The following is a description of a gene set: Human Gene Set: MISHRA_CARCINOMA_ASSOCIATED_FIBROBLAST_UP Carcinoma-associated fibroblasts (CAF) have recently been implicated in important aspects of epithelial solid tumor biology, such as neoplastic progression, tumor growth, angiogenesis, and metastasis. However, neither the source of CAFs nor the differences between CAFs and fibroblasts from nonneoplastic tissue have been well defined. In this study, we show that human bone marrow-derived mesenchymal stem cells (hMSCs) exposed to tumor-conditioned medium (TCM) over a prolonged period of time assume a CAF-like myofibroblastic phenotype. More importantly, these cells exhibit functional properties of CAFs, including sustained expression of stromal-derived factor-1 (SDF-1) and the ability to promote tumor cell growth both in vitro and in an in vivo coimplantation model, and expression of myofibroblast markers, including alpha-smooth muscle actin and fibroblast surface protein. hMSCs induced to differentiate to a myofibroblast-like phenotype using 5-azacytidine do not promote tumor cell growth as efficiently as hMSCs cultured in TCM nor do they show increased SDF-1 expression. Furthermore, gene expression profiling revealed similarities between TCM-exposed hMSCs and CAFs. Taken together, these data suggest that hMSCs are a source of CAFs and can be used in the modeling of tumor-stroma interactions. To our knowledge, this is the first report showing that hMSCs become activated and resemble carcinoma-associated myofibroblasts on prolonged exposure to conditioned medium from MDAMB231 human breast cancer cells. Top genes up-regulated in mesenchyme stem cells (MSC) grown in a tumor conditioned medium, which leads to carcinoma-associated fibroblast phenotype. studied in species Homo sapiens from publication Mishra PJ, Mishra PJ, Humeniuk R, Medina DJ, Alexe G, Mesirov JP, Ganesan S, Glod JW, Banerjee D (PMID 18519693), and this is the list of marker genes: FOS, THY1, PDGFA, PLAU (NCBI Gene Id 95176), PDGFRB, CA12, CTHRC1, CCL2 (C-C motif chemokine ligand 2), MMP9, COL6A2, TNC, TCN1, FGR, GEM, TMEM156, RAB3B, CTSK, EGR1, FXYD3, BEX5, HBA2, COL6A1, KRT17, SESN2